The following is a description of a gene set: Mouse Gene Set: TABULA_MURIS_SENIS_LUNG_ADVENTITIAL_CELL_AGEING studied in species Mus musculus from publication Tabula Muris Consortium (PMID 32669714), and this is the list of marker genes: Ifitm2, Psmb4, Ftl1, Nfkbia, Cdkn1a, Idh2, Csnk2b, Rabac1, Tspo, Sod2, Gsta3, Tex261, Syf2, Npdc1, Prelid1, Cyba, Tbcb, Ier2, Pomp, B2m (beta-2 microglobulin), Tmt1a, Ddrgk1, Dad1, H2-Aa, Cacybp, Rnf5, Cox5a, Selenok, Gpx3, Irf8, Gm13889, Emd, Fas, Psma6, Cd82, Ifitm3, Dhrs3, Id3, Cdkn1c, Psmc5, Snrpc, Sf3b2, Calm2, Tubb4b, Swi5, Emp3, Bmyc, Naca, Gapdh, Rps24 (NCBI Gene Id 20088), Ces1d, Cbr1, Phb1, Atp5pb, Rps3 (NCBI Gene Id 52418), Tnfsf13b, Pnp, Eif3m, Wbp2, Trf, Bsg, Phlda3, Rbm42, Hsp90ab1, Dlgap4, Rbm25, Tmed9, Eif3g, Litaf, Tmem59, Calm1, Ptma, Snx3, Map1lc3a, Psmd4, Bax, Lamtor2, Babam1, Znhit1, Spcs2, Nabp2, Psma5, Ap2s1, Ndufv1, Selenos, Smarcb1, Psmb2, Mydgf, Lgals3bp, Tubb6, Cdk2ap2, Sdf2l1, Rhoc, Myl9, Npm1, Arpc3, Crip2, H2-D1, Cryab, Psmd6, Rpl6, S100a9, Mt1, Selenbp1, Adrm1, Pebp1, Mdh2 (NCBI Gene Id 17448), Snrpb, Spr, Anxa1, Cyb5a, Txn2, Nsg1, Tmem50a (NCBI Gene Id 71817), S100a8, Nfkbib, Chrac1, Jund, Psme1, Apoe, Lysmd2, Cd63, Ldha, Rassf1, Fxyd6, Eif5a, Sbds, Grina, Eif3f, Rtp4, Arhgdia (NCBI Gene Id 77176), Chmp2a, Manf, Naxd, Isg15, Klf7, Edf1, Bst2, Ubb, Snrpa (NCBI Gene Id 53607), Gpm6b, Sdhc, Enpp2, Chchd2, Erp29, Tmem176a, Rbp1, Hspb1, Slc25a5, Rps10, Pfn1, Echs1, Eif5, Srsf5, Pdia6, Tsc22d1, Iscu, Tagln2, Map1lc3b, Arpc1b, Sdc4, Rpl4 (ribosomal protein L4), Ppig (NCBI Gene Id 228005), Nbl1, Tmem176b, Ifi27l2a, Sod3, Elof1, Hsp90aa1 (NCBI Gene Id 15524), Anp32b, Spon2, Psmb8, H3f3b, Hadh, Sarnp, Cd74, H2-Ab1, Ppp1r11, Nme1, Tpgs1, H2-K1, Efemp1, Dnajc3, Serbp1, Prr13, Psmd12, Cald1, Crlf2, Slc25a3, Rpl13a (NCBI Gene Id 80550), Ddhd2, Sec11a, Rpsa, Ube2l6, Myl12a, Samm50, Gm4956, Hsd11b1, Scamp3, Cfl1, BC031181, Ldhb, Ostc, Fth1, Psma2, Psmb1, Comt, Cdo1, Gyg1, Cuedc2, Acta2, Hint1, Kdelr1, Clic1, Nudc